The following is a description of a gene set: species: Mus musculus Mouse Gene Set: MIR_324_5P Genes predicted to be targets of miRBase v22 microRNA mmu_miR_324_5p in miRDB v6.0 with MirTarget v4 prediction scores > 80 (high confidence targets). from publication Chen Y, Wang X (PMID 31504780), and this is the list of marker genes: Zfp617, Ap1g1, Xpnpep3, Nf1, Tafa2, Tollip, Zfp763, Nek7, Zfp975, Prkcg, Zfp97, Psme3, Osr2, Zfp936, Nap1l1, Meox1, Gpc2, Mchr1, Mycn, Tmcc1, Abraxas2, Elavl1, Zfp976, Tmem63b, Ran, Pbx1, Ptafr, Suox, Camkv, Map4k3, Tnfrsf1a, Cuedc2